Given this list of marker genes IL7R, CD247, RAG1, RAG2, CD3E, CD3D, here is a description of the gene set: Human Gene Set: HP_FAILURE_TO_THRIVE_SECONDARY_TO_RECURRENT_INFECTIONS Insufficient weight gain or inappropriate weight loss for a child, that is attributed to an endogenous recurrent infections. species: Homo sapiens Failure to thrive secondary to recurrent infections